Given this list of marker genes Efnb2, Akt3, Nfatc3, Foxf1, Sec24b, Adamts9, Hes1, Rtn4, Nog, Mylk, Tfap2b, Mir145a, Prrx2, Prdm1, Hpgd, Kat6a (NCBI Gene Id 60407), Sox4, Hoxa13, Bmpr1a, Arid2, Hey2, Adgrf4, Smad7, Ptger4, Eya1, Prrx1, Folr1, Prox1, Tgfb2, Tgfbr1, Efemp2, Srf, Tbx1, Angptl3, Nrp1, Cited2, Zmiz1, Foxc2, Hey1, Six1, Notch3, Ldlr, Ephb4, Rbpj, Chrd, Nf1, Megf8, Edn1, Mdk, Bmp4, Notch4, Dll4, Vegfa, Lrp1, Tbx2, Wnt11, Foxc1, Fkbp10, Myocd, Jag1, Naglu, Notch1, Hoxa1 (homeobox A1), Comp, Gja5, Ctnnb1, Ednra (NCBI Gene Id 14737), Apoe, Chd7, Adgrf5, Apob, Bmpr2, Stra6, Mir143, Col3a1 (collagen, type III, alpha 1), Lrp2, Pkd2, Nprl3, Tgfbr2, Pdgfrb, Eng, Foxh1, Hand2, Acvrl1, Smarca4, Fgf8, here is a description of the gene set: Mouse Gene Set: GOBP_ARTERY_MORPHOGENESIS The process in which the anatomical structures of arterial blood vessels are generated and organized. Arteries are blood vessels that transport blood from the heart to the body and its organs. species: Mus musculus